Given this list of marker genes H2BC4, SS18L1, H2BC17, H3C1, GATAD2A, H2BC9, SMARCD2, MTA1, HDAC2, H3-3A, CHD4, H2AC18, H4C1, H2AC14, H2AX, SMARCD1, ARID1A, ACTL6A, HDAC1, SMARCC1, CHD3, BCL7B, ACTB, H2AC7, BCL7C, SPOCD1, MTA3, SMARCA4, H2AJ, H2BC15, H2BC1, RBBP7, BCL7A, H2BC12L, RBBP4, DNMT3A, ARID1B, H2BC14, H2BC3, MBD3, SMARCC2, H2BC11, MTA2, SMARCE1, H2AB1, DPF2, C19orf84, GATAD2B, SS18, SMARCB1, H2BC26, H2BC5, SMARCA2, SMARCD3, H3C15, H2AZ2, H2BC12 (NCBI Gene Id 85236), H2AC4, DNMT3L, H2BC13, PIWIL4, DPF1, H2AC20, H2AC6, DPF3, H2BC21, here is a description of the gene set: species: Homo sapiens Reactome Pathway: Regulation of endogenous retroelements by Piwi-interacting RNAs (piRNAs) PIWI-interacting RNAs (piRNAs) are short RNAs of 24-31 nucleotides that are produced by cleavage of longer RNAs and amplification by a "ping-pong" mechanism involving rounds of strand hybridization and cleavage. The piRNAs are loaded onto PIWI proteins (PIWIL1, PIWIL2, PIWIL4) that are then guided by base-pairing of the piRNAs to nascent and mature transcripts, where the PIWI:piRNA complexes initiate transcriptional and post-transcriptional silencing, respectively.<br>In mice, sources of piRNAs include transposon RNAs, long non-coding RNAs, exon transcripts, and RNAs from unannotated regions of the genome. Two populations of piRNAs are observed during mouse development: pre-pachytene piRNAs and pachytene piRNAs. Pre-pachytene piRNAs are present prenatally in prospermatogonial cells and postnatally in spermatogonial cells. Pachytene piRNAs are present in more mature postnatal spermatocytes and spermatids. The piRNAs derived from retroelements comprise about half or less of the total pre-pachytene piRNAs and the portion falls sharply from pre-pachytene to pachytene.<br>In mice, PIWIL2 (MILI, Piwil2 gene) is first detected in primordial germ cells that have reached the genital ridge and expression persists through meiosis in adults. PIWIL4 (MIWI2, PIWIl4 gene) is present in mouse germ cells during de novo DNA methylation shortly before and after birth. PIWIL1 (MIWI, PIWIL1 gene) is present during later stages of meiosis after birth. PIWIL4 and PIWIL2 participate in re-methylation of the genome in mouse germ cells and consequent repression of transposable elements. In mice, the piRNAs bound by PIWIL4 bind nascent transcripts of transposable elements and connects to the de novo DNA methylation machinery via SPOCD1 and C19ORF84 to direct DNA methylation to the transposable elements. Mutations in SPOCD1 are associated with infertility in men part of: Regulation of endogenous retroelements